Given this list of marker genes ABCD2, PSMD5, MRPL41 (NCBI Gene Id 64975), NFIL3, RGS16, P4HA1, SYT17, HSPA1B, SRSF6, CRYBG1, AVPR1A, HERPUD1, PER2, PKIB, RAB34, CCL21, REXO2, RASL11B, GADD45G, GADD45B, HSPH1, STX5, RABEP1, MAN2A1, RORA, HNRNPM, SGK1, FABP7, CRY1, GADD45A, SOX7, HSPA5, HLA-DRB1 (NCBI Gene Id 730415), PDIA6, UBFD1, RPN2, BLCAP, CAPRIN1, DBP, AKAP17A, BCKDHB, PLK2, CMBL (NCBI Gene Id 134147), DUSP1, THRAP3, CDK2AP2, RASD1, HSPD1, POLR2E, CALCR, PLEKHA1 (pleckstrin homology domain containing A1), AVP, ID2, SMPDL3A, RBM3, ORMDL1, STAT3, TMEM30A, AP1B1, MANF, IGFBP5, CXCL12, STK24 (serine/threonine kinase 24), SFRP2, UBE2S, PHKA1, PPP1R1A, TUBGCP4, RNASET2, HMGB3, HSPA1A, CHORDC1, NR1D2, XBP1, BMAL1, SQLE, BMPR1A, TPRG1L, CCL7, ZBTB14, DNAJB1, DHODH, PDCD4, HRH2, DLK1, PER1, TUBA8, UBQLN1, H3-3B, NSDHL, here is a description of the gene set: from publication Ueda HR, Chen W, Minami Y, Honma S, Honma K, Iino M, Hashimoto S (PMID 15273285) studied in species Mus musculus Detection of individual body time (BT) via a single-time-point assay has been a longstanding unfulfilled dream in medicine, because BT information can be exploited to maximize potency and minimize toxicity during drug administration and thus will enable highly optimized medication. To achieve this dream, we created a molecular timetable composed of >100 time-indicating genes, whose gene expression levels can represent internal BT. Here we describe a robust method called the molecular-timetable method for BT detection from a single-time-point expression profile. The power of this method is demonstrated by the sensitive and accurate detection of BT and the sensitive diagnosis of rhythm disorders. These results demonstrate the feasibility of BT detection based on single-time-point sampling, suggest the potential for expression-based diagnosis of rhythm disorders, and may translate functional genomics into chronotherapy and personalized medicine. Molecular timetable composed of 96 time-indicating genes (103 probes) in the central (suprachiasmatic nucleus (SCN)) clock. Human Gene Set: UEDA_CENTRAL_CLOCK